Given this list of marker genes HAS2, HAS1, CD44, HYAL1, GUSB, HEXA, HAS3, HYAL3, LYVE1, SLC17A5, HEXB, STAB2, CEMIP, HYAL4, SPAM1, CHP1, ABCC5, HYAL2, SLC9A1, HMMR, here is a description of the gene set: species: Homo sapiens Hyaluronan (hyaluronic acid, hyaluronate or HA) is an anionic glycosaminoglycan (GAG) distributed widely throughout connective, epithelial, and neural tissues and most abundant in the extracellular matrix and skin. HA is unique among the GAGs in that it is not sulfated and is not found covalently attached to proteins as a proteoglycan. HA polymers are very large (they can reach molecular weights of 10 million Da) and can displace a large volume of water making them excellent lubricators and shock absorbers. Another unique feature of HA is that it is synthesized at the plasma membrane unlike other GAGs which are formed in the Golgi. HA is a polymer of the disaccharide unit D-glucuronic acid and D-N-acetylglucosamine, linked via alternating beta-1,4 and beta-1,3 glycosidic bonds. Reactome Pathway: Hyaluronan metabolism part of: Glycosaminoglycan metabolism